The following is a description of a gene set: Mouse Gene Set: GOBP_RESPONSE_TO_PLATELET_DERIVED_GROWTH_FACTOR Any process that results in a change in state or activity of a cell or an organism (in terms of movement, secretion, enzyme production, gene expression, etc.) as a result of a platelet-derived growth factor stimulus. studied in species Mus musculus, and this is the list of marker genes: Has1, Pdgfb, Pparg, Arpc2, Has2, Ccna2, Prkce, Snai2, Tlr4, Hyal1, Iqgap1, Ptprd, Itgb3, Fer, Pdgfrb, Yes1 (NCBI Gene Id 22612), Mtss2, Spon2 (spondin 2, extracellular matrix protein), Cbl, Mars1, Ptpn1, Rasa1, Ddit3, Syap1, Fyn, Atp7a, Ccl2, Enpp1, Pdgfd, Src, Coro1b (NCBI Gene Id 23789)